Given this list of marker genes DSC3, CWF19L1, PITPNC1, HNRNPF, ISG20, TRAPPC2, GABARAPL1, GOLIM4, MYH7, DNAI7, ERC2, ZNF281, RMND5A, IGFBP3, RHOB, ACVR1B (NCBI Gene Id 93351), PKMYT1, PCTP, XAF1, HCK, INPP5B, MLLT10, SPO11, H2BC4, KDM5A, BIK, SSH1, BTF3P12, GFI1B, FGF5, RABIF (NCBI Gene Id 5877), CUTC, CTCF, KIF5A, CES3, CXCR4, ZNF587, NOX4, GRK6, CASC3, ITPKB, MSRB1, NHERF1, CORIN, TSPOAP1, GPR12, CNOT8, C3AR1, C11orf71, KIF13A, PHF20, YOD1, ARHGEF6 (Rac/Cdc42 guanine nucleotide exchange factor 6), GNAQ, HRH2, ESYT1, IFITM1, TESC, DENND3, FPR1, H3-3B, PRR7, DLGAP1, IFIT5, SERPINA2, SMIM14, APOC4, DDIT3, MEIS2, RHOBTB3, PDLIM2, PIK3CG, SETDB1, EDA2R, GIT2, PRLH, GAL3ST4 (galactose-3-O-sulfotransferase 4), DELEC1, KLF3, TEAD3, DAPP1, ANKRD17, CYTH1, MAP1LC3B, EIF1, CTDSP2, DCLRE1C (DNA cross-link repair 1C), RGS9, GRB10, ZNF75D, UGT2B28, CPA3, ESPN, AMPD3, TSPYL2, FAM117A, TSGA10, THBS4, KBTBD11, XAB2, ASB4, RABGEF1, TMEM131L, MYD88, CACNA1S, RPL34, RHOH, ZNF586, MCTP2, CDH15, PHACTR1 (phosphatase and actin regulator 1), TACC1, CYRIA, ACACB, CYLC2 (NCBI Gene Id 1539), CD34, RLF (RLF zinc finger), CHST2, RPL36AL, SYNE2, KIF21B, PDE1C, EIF4EBP2, PPP1R15A, C2orf68, GVINP1, FLRT3, PTEN, LRRFIP1, HSPA1L, SLC4A8, DNAH3, RNASE2, FAM184A, IFITM2, ENSA, TKTL1, PRF1, RGS14 (regulator of G protein signaling 14), MRPL49, AURKA, CD244, IDO1, TPM3, PYGL, S100P, INPP5A (inositol polyphosphate-5-phosphatase A), PAPSS1, KRTAP1-1, SYNE1, CHP1, NOTCH1 (notch receptor 1), STAP1, RBM14, ZNF350, PPP4R3B, TNFRSF10C, CFD, RERGL, STK17B, S1PR1, XRCC2, MTPAP, SRRT, IL13RA2, SEC61G, CENPA, PCF11, CCR3, SKP2, RRAD, GABARAPL2 (NCBI Gene Id 90769), IRF1, IL5RA, PODNL1, CNTN5, TUT4, ANKRD27, MLF1, JAK1, TFDP1, APOH, PPP1R16B, KDM6B, COL14A1 (collagen type XIV alpha 1 chain), ERCC6, SLC6A16 (NCBI Gene Id 95514, solute carrier family 6 member 16), THYN1, C21orf91, LPIN2, WIPI1, VN1R1, CHRNB2, IL9R, ZNF562, NADK, ADGRE2, JARID2, NDUFA4L2, here is a description of the gene set: Genes up-regulated in comparison of eosinophils versus dendritic cells (DC). from publication Jeffrey KL, Brummer T, Rolph MS, Liu SM, Callejas NA, Grumont RJ, Gillieron C, Mackay F, Grey S, Camps M, Rommel C, Gerondakis SD, Mackay CR (PMID 16474395) In the present study we used Affymetrix oligonucleotide microarrays to produce gene transcription profiles for the major leukocyte types in humans. This comprehensive dataset enabled us to not only establish which genes were expressed in each leukocyte type, but also which genes were expressed in each subset after activation. The used of a comprehensive dataset of gene profiles from all the major human leukocyte subsets enabled a novel and powerful means for identification of genes associated with single leukocyte subsets, or different immune paradigms. Human Gene Set: GSE3982_EOSINOPHIL_VS_DC_UP studied in species Homo sapiens